The following is a description of a gene set: part of: Extra-nuclear estrogen signaling Although membrane-localized estrogen receptors stimulate rapid, transcription-independent responses such as calcium mobilization and alterations to the fibronectin matrix to affect cell migration, among others, the pathways activated by rapid signaling may also ultimately affect nuclear events. Activation of MAPK and PI3K/AKT pathways downstream of membrane-localized ESR1 contributes to estrogen-responsive changes in cellular proliferation and survival in part through changes in gene expression. Reactome Pathway: Estrogen-dependent nuclear events downstream of ESR-membrane signaling studied in species Homo sapiens, and this is the list of marker genes: CREB1, FOXO3, CDKN1B, BTC, AKT1, FOS, MAPK1, AKT2, PTK2, EGFR, ELK1, EGF, XPO1, EPGN, MAPK3 (NCBI Gene Id 5595), HBEGF, CCND1, UHMK1, EREG, AKT3, TGFA, SRF, BCL2, AREG